The following is a description of a gene set: Human Gene Set: REACTOME_MECHANICAL_LOAD_ACTIVATES_SIGNALING_BY_PIEZO1_AND_INTEGRINS_IN_OSTEOCYTES species: Homo sapiens Mechanical load activates signaling by PIEZO1 and integrins in osteocytes, and this is the list of marker genes: CACNB1, CACNB2, CACNA2D1, CACNB3 (calcium voltage-gated channel auxiliary subunit beta 3), HSPG2, CACNA1H, ITGA5, CACNG7, PANX1 (pannexin 1), ITGB3, ITGB1, ITGAV, P2RX7, GJA1, AKT1, PIEZO1 (piezo type mechanosensitive ion channel component 1 (Er blood group)), SPP1